Given this list of marker genes Ube2l6, Tmem19, Tap1, Iigp1, Gbp5, Pml, Igtp (NCBI Gene Id 16145), Gbp7, Ifi47, Eral1, Rtp4, Plaat3, Isg15, Grk6, Tapbp, Ifit1, Gbp6, Ly6a, Irf1 (interferon regulatory factor 1), B2m, Stat1, H2-T23, Gbp3, Phf11b, Bst2, Parp9, Gbp2, Socs1, here is a description of the gene set: species: Mus musculus Cytokines mediate cell-cell communication in the immune system and represent important therapeutic targets. A myriad of studies have highlighted their central role in immune function, yet we lack a global view of the cellular responses of each immune cell type to each cytokine. To address this gap, the authors created the Immune Dictionary, a compendium of single-cell transcriptomic profiles of more than 17 immune cell types in response to each of 86 cytokines (>1,400 cytokine-cell type combinations) in mouse lymph nodes in vivo. A cytokine-centric view of the dictionary revealed that most cytokines induce highly cell-type-specific responses. For example, the inflammatory cytokine interleukin-1β induces distinct gene programmes in almost every cell type. A cell-type-centric view of the dictionary identified more than 66 cytokine-driven cellular polarization states across immune cell types, including previously uncharacterized states such as an interleukin-18-induced polyfunctional natural killer cell state. Mouse Gene Set: CUI_MAST_CELL_IFNG_RESPONSE_UP Genes positively differentially expressed in cell type: Mast cell upon treatment with cytokine: IFN-γ in mouse lymph nodes in vivo. from publication Cui A, Huang T, Li S, Ma A, Pérez JL, Sander C, Keskin DB, Wu CJ, Fraenkel E, Hacohen N (PMID 38057668)